Given this list of marker genes ABCB5, ENSG00000260592, HBE1, FECH, SLC25A37, ENSG00000181123, HDC, DHRS13, ITLN1, HBG1, HBA1, SLC14A1, BLVRB (biliverdin reductase B), HEMGN, NARF, FAM167A-AS1 (NCBI Gene Id 83656), GYPE, EPB41, TRIM10, HECTD4, TRAK2, E2F2, SMCO3, ENSG00000189316, RHD, RWDD3-DT, CDK15, SPMAP2L, SELENBP1, SCYL2P1, RNF224, GCLC, ESPN (NCBI Gene Id 83715), LINC02772, DPF3, TDH, TLCD4-RWDD3, KLF1, LINC02506, SLC4A1, TPSAB1, SLC22A4, PKLR, PHOSPHO1, TPSB2, TENT5C, IBA57, SEC14L4, XACT, EIF5AP2, TFR2, HMGN1P1, C17orf99, TSPAN5, ABCB10 (NCBI Gene Id 23456), HBB, RSAD2, PRG2, GALNT5, ANK1, ALAD, ERMAP, ABCC13, PPOX, EPB42, PTH2R, SPECC1, HBM, CTSE, PPME1, IFIT1B, TSPO2, HBQ1, HBZ, FAM178B, MARCHF8, CD46P1, RNF123, SLC25A39, HNF4A-AS1, KRT1, H2AC8 (NCBI Gene Id 3012), ERVE-1, ACKR1, YPEL4, ALAS2, SLC22A16, KRT13, ARG1, SPTB, RHCE, BGLT3, CPOX, TSPAN5-DT, XPO7, HBG2, ST6GALNAC1, LINC01399, HBBP1, TMCC2, GYPB, RFESD, CA1, HBA2, GLRX5, AHSP, CAT, ART4, TLCD4, SLC25A21, ACSL6 (NCBI Gene Id 56972), DYRK3, PIGQ, SPTA1, SOX6, PRSS51, GYPA, here is a description of the gene set: studied in species Homo sapiens The gene expression program underlying the specification of human cell types is of fundamental interest. The study authors generated human cell atlases of gene expression and chromatin accessibility in fetal tissues. For gene expression, the study authors applied three-level combinatorial indexing to >110 samples representing 15 organs, ultimately profiling ~4 million single cells. The study authors leveraged the literature and other atlases to identify and annotate hundreds of cell types and subtypes, both within and across tissues. Our analyses focused on organ-specific specializations of broadly distributed cell types (such as blood, endothelial, and epithelial), sites of fetal erythropoiesis (which notably included the adrenal gland), and integration with mouse developmental atlases (such as conserved specification of blood cells). These data represent a rich resource for the exploration of in vivo human gene expression in diverse tissues and cell types. Marker genes curated from the annotated cluster as represented in the Descartes Human Gene Expression During Development database. from publication Cao J, O'Day DR, Pliner HA, Kingsley PD, Deng M, Daza RM, Zager MA, Aldinger KA, Blecher-Gonen R, Zhang F, Spielmann M, Palis J, Doherty D, Steemers FJ, Glass IA, Trapnell C, Shendure J (PMID 33184181) Human Gene Set: DESCARTES_FETAL_ADRENAL_ERYTHROBLASTS